The following is a description of a gene set: Human Gene Set: GSE11864_UNTREATED_VS_CSF1_IFNG_PAM3CYS_IN_MAC_UP from publication Hu X, Chung AY, Wu I, Foldi J, Chen J, Ji JD, Tateya T, Kang YJ, Han J, Gessler M, Kageyama R, Ivashkiv LB (PMID 18976936) Gene expression analysis of freshly isolated CD14+ human monocytes and monocytes cultured in the presence or absence of interferon (IFN) -gamma for 24 h and then stimulated with Pam3Cys, a Toll-like receptor (TLR) 2 ligand, for 6 h. Results provide insight into mechanisms by which IFN-gamma reprograms early macrophage differentiation and subsequent response to TLR ligands. studied in species Homo sapiens Genes up-regulated in comparison of untreated macrophages versus those cultured with M-CSF, IFNG and Pam3Cys (TLR2 agonist)., and this is the list of marker genes: STUB1, TMUB2, DOCK5, ARIH2OS, USP39, MARCHF2, CTDSP2, SNHG16, PYM1, MYG1, ST6GALNAC3, SLC44A2, SYNE3, SH3BGRL, VAV2, VCPKMT, HDDC3, TGOLN2, ID3, CD99P1, TSC2, COTL1, OXR1, ACSS1, ZBED4, L3HYPDH, MYCL, C11orf21 (chromosome 11 open reading frame 21), CALHM2, NLRP12, HACD2, AFF1, USP48, SGSM2, ARRB2, BRD3OS, UNC93B1, SET, AP1S2, ZBED10P, ZNF852, SEC62, TMC4, TFAM, NTNG2, PAFAH1B3, SNX2, GMFG, IFT27, BNIP3L, GASK1B, HNRNPM, RP9, UBE2D3, STAC3, BBS9, VPS45, USP15 (ubiquitin specific peptidase 15), BCAS3, CHMP1B, TBPL1, ARID1A, DENR (density regulated re-initiation and release factor), CCDC59, PHB2, KANSL2, KIAA2013, ING2, RPS7, GSTK1, TCEA1, ANP32B, SYTL2, UBL7, GPBAR1, EPHB6, PDE4D, JDP2, ABHD14B, C16orf86, ARHGEF1, VIPR1, KATNB1, XYLT1, SLC35A1, C10orf95-AS1, PGP, PDSS2, ERN1 (NCBI Gene Id 63433), HGF, LEPR, PLB1, ZC3H7A, PRKRA, FGFBP2, MCCC1, ARPC1B, TMTC2, LAPTM5, GK5, GNAI2, PCYOX1, RMDN2, GLB1, SERTAD2, FAM13B, SULT1B1, BAG2, GRSF1, CD4, SARAF, MTHFR, PRPF31, ALKBH4 (NCBI Gene Id 54784), ANKDD1A, HLA-F-AS1, SSBP3, MGST2, FKBP1A (NCBI Gene Id 2280), NPRL2 (NCBI Gene Id 10641), EPB41L4A-AS1, IRAK4, VPS8, TST, C4orf3, ABRAXAS1, STK38, FIG4, OLA1, ZFTRAF1, CRISPLD1, PARP16, CENPU, WDR45B, FAM210B (family with sequence similarity 210 member B), TBC1D17, ERCC5, CIB1, CHN2, C1orf52, PARL, KTI12 (NCBI Gene Id 112970), RASA3, S100A8, PEX5, MAGED1, ST20-AS1, MAPRE2, CRBN, SNAPC3, H2BC11, SORCS2, RPL9, SUCLG2, CCNH, TPGS2, TRIM11, XGY2, NTPCR, RUSC1, NUDT16L2P, NICN1, XRCC5, CAMK1D, LYPLA1, RBL2, AGO4 (argonaute RISC component 4), GLIPR1, ZNF124, MPST, SORD, UIMC1, TBCC, EXT1, DDX46, KIF3C, MRPS27, PTPRA, HMGB3P1, NFYC-AS1, DNAJC9, SEPTIN7P14, RSRC2, TMEM59, ADISSP, BRD3, RETREG1, SFPQ, ENSG00000236854 (novel transcript), FAM149B1, PAK1, HNRNPUL1, METTL5, ABTB3, TBC1D5, WDR54, RNF11, MAP1LC3B